Given this list of marker genes Gsk3a, Pomc, Mrap2, Adrb1, Nos1, Mrap, here is a description of the gene set: Any process that activates or increases the frequency, rate or extent of an adenylate cyclase-activating G protein-coupled receptor signaling pathway. studied in species Mus musculus Mouse Gene Set: GOBP_POSITIVE_REGULATION_OF_ADENYLATE_CYCLASE_ACTIVATING_G_PROTEIN_COUPLED_RECEPTOR_SIGNALING_PATHWAY